Given this list of marker genes Cpeb1 (cytoplasmic polyadenylation element binding protein 1), Eif4ebp1, Dhfr, Ifrd2, Tyms, Cpeb4, Pura, Cirbp, Serbp1, Purb, Eif4ebp2, Cpeb3, Mir9-1, Cyfip1, Patl2, Ireb2, Bc1, Rara, Fmr1, Dapl1, Samd4b, Nanos1, Paip2b, Mirlet7g, Patl1, Samd4, Paip2, Cpeb2, Shmt1 (serine hydroxymethyltransferase 1 (soluble)), Mir135a-1, Trim71, here is a description of the gene set: species: Mus musculus Mouse Gene Set: GOMF_TRANSLATION_REPRESSOR_ACTIVITY Antagonizes ribosome-mediated translation of mRNA into a polypeptide.